The following is a description of a gene set: species: Mus musculus Mouse Gene Set: GOMF_RIBOSOME_BINDING Binding to a ribosome., and this is the list of marker genes: Srp72, Nmd3, Sec61g-ps2, Pim1, Letmd1, Sec61g-ps3, Ifrd2, Eif2a, Habp4, Nomo1, Slfn4 (schlafen 4, NCBI Gene Id 20558), Naa10, Ighmbp2, Eif2s1, Dnajc2, Pttg1, Rack1, Eif1, Ndufab1, Rpn2, Eif3k, Ttc5, Tmco1, Ncln, Mtif2, Tmem223, Npm1, Mtres1, Stau2, Srp68, Taco1, Zc3h12a, Efl1, Fmr1, Slfn1, Gemin5, Unk, Dhx29, Dapl1, Cpeb1, Uqcc5, Eef2, Cpsf6, Rps21, Letm2, Nemf, Eif5a2, Uchl1, Ccdc47, C1qbp, Mrrf, Mtor, Larp1, Slfn2, Eri1, Eif5a, Ung, Ddx3x, Mettl17, Mcts1, Rbm3, Eif4h, Sec61a1, Cpeb4, Abcf1, Cpeb3, Dnajc1, Guf1 (NCBI Gene Id 231279), G3bp1, Serbp1, Eif4b, D1Pas1, Nme1, Gtpbp6, Ptcd3, Dhx9, Maip1, Abce1, Mtif3, Mrps27 (mitochondrial ribosomal protein S27), Spcs1, Pym1, Zfp598, Sec61a2, Eral1, Naa15, Eif1a, Ythdf1, Ola1, Dap, Eif1b, Rictor, ENSMUSG00000131459, Ythdf3, Malsu1, Dhx33, Oxa1l, Ltn1, Sbds, Map3k20, Rpsa, Ndufab1-ps, Sec61g, Eif3c, Mtrfr, Shfl, Naa16, Sec61b, Srp19, Tmem147, Slfn14, Usp16, Sec61bl, Eif6, Impact, Slfn3, Letm1, Cpeb2, Pelo, Bag6, Hspa5